Given this list of marker genes TRIM14, RIN2, ISG15, IFITM2, IFI35, HERC5, IFI44, LY6E, GBP1, STAT2, FBXO6, MX2, OASL, OAS1, NEXN, IL1RN, SCO2, IFIT5, DDX60, IFIT3, MX1, IFIT1, CCR1, MT2A, RTP4, RIGI, PARP12, TRIM22, USP18, ZBP1, TOR1B, TNFSF10, IFI6 (interferon alpha inducible protein 6), PARP14, SAMD9L, CMPK2, HERC6, PARP9, RNF213 (NCBI Gene Id 79398), ETV7, IFIT2, SERPING1, CXCL10, IFIH1, SAMD9, ZCCHC2, IFI44L, IFI27, TRIM5, MAFB, SHISA5, LAP3, SPATS2L (NCBI Gene Id 26010), TNFAIP6, EPSTI1, OAS2, UBE2L6, PPM1K, SIGLEC1 (sialic acid binding Ig like lectin 1), PNPT1, MS4A4A, BLVRA, DDX60L, RSAD2, IFITM1, EIF2AK2, APOL6, PLSCR1, IRF7, OAS3, XAF1, LAMP3, here is a description of the gene set: species: Homo sapiens from publication Erwin-Cohen RA, Porter AI, Pittman PR, Rossi CA, DaSilva L (PMID 27870591) Human Gene Set: ERWIN_COHEN_BLOOD_VACCINE_TC_83_AGE_23_48YO_VACCINATED_VS_CONTROL_7DY_UP Genes up-regulated in blood vaccinated vs control in adults (23-48) after exposure to Live attenuated vaccine TC-83, time point 7D Venezuelan equine encephalitis virus (VEEV) is an important human and animal alphavirus pathogen transmitted by mosquitoes. The virus is endemic in Central and South America, but has also caused equine outbreaks in southwestern areas of the United States. In an effort to better understand the molecular mechanisms of the development of immunity to this important pathogen, we performed transcriptional analysis from whole, unfractionated human blood of patients who had been immunized with the live-attenuated vaccine strain of VEEV, TC-83. We compared changes in the transcriptome between naive individuals who were mock vaccinated with saline to responses of individuals who received TC-83. Significant transcriptional changes were noted at days 2, 7, and 14 following vaccination. The top canonical pathways revealed at early and intermediate time points (days 2 and 7) included the involvement of the classic interferon response, interferon-response factors, activation of pattern recognition receptors, and engagement of the inflammasome. By day 14, the top canonical pathways included oxidative phosphorylation, the protein ubiquitination pathway, natural killer cell signaling, and B-cell development. Biomarkers were identified that differentiate between vaccinees and control subjects, at early, intermediate, and late stages of the development of immunity as well as markers which were common to all 3 stages following vaccination but distinct from the sham-vaccinated control subjects. The study represents a novel examination of molecular processes that lead to the development of immunity against VEEV in humans and which may be of value as diagnostic targets, to enhance modern vaccine design, or molecular correlates of protection.